Given this list of marker genes ABCD2, PEX14, PEX19, PEX16, FIS1, ABCD1, PEX12, PXMP2, PEX11B, ALDH3A2, PEX2 (NCBI Gene Id 5828), PEX3, GDAP1, PXMP4, PEX13, PEX26, ABCD3, SLC25A17, ATAD1, ACBD5, here is a description of the gene set: Human Gene Set: REACTOME_CLASS_I_PEROXISOMAL_MEMBRANE_PROTEIN_IMPORT Class I peroxisomal membrane protein import studied in species Homo sapiens